Given this list of marker genes SLN, ZFAND5, ISL1, ST20-AS1, MAFF (NCBI Gene Id 23764), HS6ST2, TAOK2, RPS29, PACRGL, VIP, ICA1, TOP1, PBXIP1, PPP1R15A, TP53TG5, JUN, GPBP1, ABR, HMGB4, TMEM270, ORAI1, TIPRL, CREB5, PER1, NFATC1, GEM, VPS37B, CBX8, SCN3B, TRIM39, ADAM11, HSD11B1, AREG, CCNI, PDP1, DOK1, IRF2BPL, GPR3, CACNA1G, SRPRA, OSR1, CHGB (chromogranin B), PFAS, CDC20B, SPEG, FAM219A, SCG2, MAPRE1, LMO4, MAP3K13, DHX36, SULT4A1, NOL4 (NCBI Gene Id 8715), ELOVL5, HSP90AB1, MAP1B, PPP2R2A, ADCY8, BRSK1, ADRA1B, CNN3, STARD13, FOSB (FosB proto-oncogene, AP-1 transcription factor subunit), CCDC148, FOXD3, PTPRU, MYL6, ABCE1, DMP1, SPI1, ING4, AKAP3, RPL4, BNIP3L, CRH, PAK6, GPM6B, STRIP1, PNMA6A, DUSP10, EIF1, TMEM147, KLF13, CCIN, TSPAN7, CYSTM1, CLDN6, ZNF367, OLFML2A, PITPNC1, ATF3, TMEM39A, CTC1, BRAF (NCBI Gene Id 673), TNFRSF12A, IRX6, DUSP3, FAM81B, CREM, NSD3, TRIB1, TRAF4, CMSS1, YME1L1, PNRC1, RAB25, DCTN1, EPHA2, EEF2, LMO3 (NCBI Gene Id 55885), CYLD, FOXRED1, NUP214, PLCD3, RUSC1, INSM1, RBKS, ZNF593, GGPS1, OLIG2, DAAM2, AHI1, JUND, ATP6V0C, ZFP36L1, CIMAP1C, NPPC (NCBI Gene Id 4880), SLC18A2, IRX4, RAI1, TRIM8, FAM174A, TNFRSF19, DNAJC1, FAXC, PNMA3, ZNF184, IL21R, CDC42, ANAPC10, RING1, YWHAZ, FAM78A, HHIP, HAS1, GARIN1B, PAK3 (p21 (RAC1) activated kinase 3), HERC1, BSDC1 (NCBI Gene Id 55108), NDEL1, PPFIBP1, FAM131A, GPR42, UCN, MAP1LC3A, MBNL2, GLYR1, ZDHHC8, PITPNA, LDHA, MBNL1, DNAI1, ASB17, TBC1D32, PRR3, FLRT3, UBQLN3, GNL1, HOXC10, SLC44A4, KMT2E, C11orf87, WFDC3, PHACTR3, CD2AP, ATG5 (autophagy related 5), DES, ZWILCH, CFL2, NDST4, CORO6 (NCBI Gene Id 84940), GPR162, DUSP1, PPM1A, CD37, THOC1, DNAJB5, LGR5, HS3ST2, MXD1, PPARGC1A, RUNDC3A, FBXW11 (NCBI Gene Id 23291), CHPF, SIK1, DDX51 (NCBI Gene Id 317781), CCNA2, CCN4, GDNF, BABAM2, ABHD16A, MXRA8, ARID4B, PHOX2B (NCBI Gene Id 8929), UBE2B, TJP1, IGF1, ACSBG2, PKP4, SST, SUV39H2, TNFRSF21, TUBB2B, NCDN, IKBKB (NCBI Gene Id 3551), GSE1, CDX4, RNF44, RPRD1A, AGPAT4, ABLIM2, SGIP1, NR2E1, WNT4, AKIRIN1, CLSTN3, PPP2R5B, RUSC1-AS1, EHD1 (EH domain containing 1), BARHL1, PAFAH1B1, PLEKHA1, ADAP1, DAAM1, CCND1, IL11, KCNN2, SORT1, HID1 (NCBI Gene Id 80791), UBE2H, MCAM, MITF (NCBI Gene Id 7487), ZSWIM8, RFX1, KLF9, HAUS2 (HAUS augmin like complex subunit 2), ILRUN (NCBI Gene Id 79138), CLCN5, CDKN1A, RCE1, BCL6, ADARB2, RNF166, here is a description of the gene set: Human Gene Set: ATF3_Q6 Genes having at least one occurrence of the motif CBCTGACGTCANCS in the regions spanning 4 kb centered on their transcription starting sites. This matches the ATF3 transcription factor binding site V$ATF3_Q6 (v7.4 TRANSFAC). studied in species Homo sapiens